Given this list of marker genes Cd180, Ncf1, Atf3, Ighm, Egr1, Tbc1d4 (NCBI Gene Id 545073), Zfp36, Fos, Adgre1, Eef2, Niban1, Abca9, Dusp1, Ccrl2, Npm1, Egr2, Klf2, Il6ra, Zeb2, Cox7a2l, Btg2, Mcemp1, Klf6, Asap1, St8sia6, Pmaip1, Marveld1, Fosb (NCBI Gene Id 14282), H2-DMa, here is a description of the gene set: Genes negatively differentially expressed in cell type: cDC2 (conventional dendritic cell type 2) upon treatment with cytokine: CT-1 in mouse lymph nodes in vivo. species: Mus musculus Mouse Gene Set: CUI_CDC2_CARDIOTROPHIN_1_RESPONSE_DN from publication Cui A, Huang T, Li S, Ma A, Pérez JL, Sander C, Keskin DB, Wu CJ, Fraenkel E, Hacohen N (PMID 38057668) Cytokines mediate cell-cell communication in the immune system and represent important therapeutic targets. A myriad of studies have highlighted their central role in immune function, yet we lack a global view of the cellular responses of each immune cell type to each cytokine. To address this gap, the authors created the Immune Dictionary, a compendium of single-cell transcriptomic profiles of more than 17 immune cell types in response to each of 86 cytokines (>1,400 cytokine-cell type combinations) in mouse lymph nodes in vivo. A cytokine-centric view of the dictionary revealed that most cytokines induce highly cell-type-specific responses. For example, the inflammatory cytokine interleukin-1β induces distinct gene programmes in almost every cell type. A cell-type-centric view of the dictionary identified more than 66 cytokine-driven cellular polarization states across immune cell types, including previously uncharacterized states such as an interleukin-18-induced polyfunctional natural killer cell state.